Given this list of marker genes SNCA, ADIPOQ, PTPN2, NDRG4, LRP1, PTPN12, MYOCD, PTPRJ, APOD (NCBI Gene Id 347), NHERF1, PHF14, PTGIR, HGS, here is a description of the gene set: Any process that stops, prevents, or reduces the frequency, rate or extent of the platelet-derived growth factor receptor signaling pathway. species: Homo sapiens Human Gene Set: GOBP_NEGATIVE_REGULATION_OF_PLATELET_DERIVED_GROWTH_FACTOR_RECEPTOR_SIGNALING_PATHWAY